The following is a description of a gene set: species: Mus musculus Mouse Gene Set: GOBP_PROTEIN_RETENTION_IN_GOLGI_APPARATUS The retention of proteins within the Golgi apparatus. Golgi-localized carbohydrate-modifying enzymes have a short N-terminal domain that faces the cytosol, a single transmembrane alpha helix, and a large C-terminal domain that faces the Golgi lumen and that contains the catalytic site. How the membrane-spanning alpha helix in a Golgi enzyme causes its localization and prevents its movement to the plasma membrane is not known., and this is the list of marker genes: Vps13c, Vps13d, Golph3, Sorl1, Vps13a